The following is a description of a gene set: Human Gene Set: GOBP_MORPHOGENESIS_OF_EMBRYONIC_EPITHELIUM The process in which the anatomical structures of embryonic epithelia are generated and organized. species: Homo sapiens, and this is the list of marker genes: TSC1, SIX4, BMP5, LLGL2, CDK20 (NCBI Gene Id 23552), RARG, MTHFD1L, RET, MIB1 (NCBI Gene Id 57534), TGFB1, NUP50, ADM, GDNF, PTCH1, OVOL2, PALS1, PFN1, TCTN1, STIL, SALL4, TEAD2, CFL1, BRD2 (bromodomain containing 2), SOX8, TGIF1, RARA, LHX2, SUFU, FGFR2, LRP2, PAX2, VEGFC, PTK7, ALX1, TULP3, TMED2, STK4, RPS7, SULF1, PDX1, MKS1, KAT2A, KDM2B, DLC1, WNT4, OSR1, HAND1, HES5, DVL2, WNT2B, SEMA4C, CECR2, GRHL2, IFT57, SHH, BMP7, TP63, PLXNB2, SLC39A12, SOX11, FGF10, GREM1, WNT9B, TRAF6, CC2D2A, LAMA5, BCL10, CLUAP1, APAF1, FUZ, PRKACB (NCBI Gene Id 5567), OPA1, SPECC1L, FZD6, KDF1, HIF1A, TRIM71, SOX9, LMO4, COBL, EPB41L5, GDF7, DVL1, ST14, NOG, IFT52, GLMN, SDC4, TFAP2A, MTHFR, SFRP1, IRX2, WDR83, TBX18, TSC2, PHACTR4, STK3, WNT5A, SFRP2, WNT16, RGMA, WNT7B, FZD3, FGF8, SEC24B, SPINT2, PCDH8, IFT122, PRICKLE1, WNT2, SCRIB, HNF1B, CTNNB1, IFT172, TGFB1I1, PAX8 (paired box 8), IRX3, RDH10, GRSF1, JAG2, RALA (RAS like proto-oncogene A), CITED2, NCKAP1, BBS4, GATA3, WNT6, TGFB2, SPINT1, SIX1, LUZP1, AR, SKI, DEAF1, VANGL2, ARHGAP35, LIAS, KIF20B, FOLR1, BMP4, MTHFD1, VASP, HS2ST1, MED12, CTHRC1, PRKACA, CASP3 (caspase 3), TWIST1, NODAL (NCBI Gene Id 8114), ALDH1A3, ABL1, ZEB2, CELSR1, GRHL3, IRX1, ALDH1A2